Given this list of marker genes NCKIPSD, ST6GAL2, SAMD4A, RIMS1, PDLIM4, FOXP2, AKAP5, CYP39A1, GBP2, BACE2, RMC1, LSS, PRKAR2B, ZNF516, MYOCD, SPEG, KCTD5, CDK8, PRELID3B, HMGA2, GNAZ, KIF21B, FBXL15, SH3PXD2B, SIPA1L1, NXN, ATL1, ALKAL2, MTHFD2L, BCAS4, PODXL2, MXRA7, PHF13, HPSE2 (NCBI Gene Id 7354), C6orf226, KLHL4, CCDC88C, IRAG1, COQ10A, RALGPS2, ETHE1, CDK5, SYNC, DIXDC1, CDKL5, LAMA5, TMEM65, ZNF649, NR4A3 (NCBI Gene Id 8013), CHD1L, PHLDA3, RYBP, KLF7, ANGPTL2, MSRB3, HHIP, BEX1, BNC2, SRF, ELAC2, RASD2, IGSF3, AKIP1, BCL11A, HSD17B14, KIAA1217, SARM1, CPNE2, MIER2, ABCC1, TAF10, FBN2, BMPR1B, KLHL42, SEC11C, PDLIM3, UBE2H, FLNB, POU2F1, PAWR, GEMIN7, PICK1, NEGR1, HACD1, MALL, CRISPLD2, ADO, CASP9, ARC, PIK3C2B, CRIM1, KIF1B, NHSL3, NSG1 (neuronal vesicle trafficking associated 1), ITGB1BP2, JPH2, ADAMTS19, GREM2 (gremlin 2, DAN family BMP antagonist), CADM4, B3GALNT2, HEPH, MOAP1, PTPRF, MYEF2, FENDRR, SVIP, SLC27A6, CCNQ, CDH2, NTF3, OSTM1, FSD1, MDM1, MBNL1-AS1, HAGH, CAMTA2, CRABP2, DNM2, NT5DC3, EDN3, PITX2, BTN2A1 (NCBI Gene Id 11120), PACSIN2, HSPG2, CXXC4, HOXA4, MMP11, PGF, C12orf75, TOMM34, SLC8A1, P2RY1, ADAMTS6, SUPT3H, TOX, SOWAHC, RGS17, NTN1, FRZB, GTF2IRD1, SNTA1, MACROD2, PCP4L1, RPS6KA5, UBE2M, TSTD1, ACTG2, ENTPD1, ALKAL1, TSPAN2, NKD1, PTCH2, SYTL2, TOM1L1, SOX15, SYNJ2, ABHD8, WASF1, CDON, EXOSC6, PRKCE, BEX2, LRIG1, DRD2, BOK, PSEN2 (presenilin 2), RHOQ, CRMA, VEGFC, DEAF1, GARNL3, SIAH2, ZNF48, ARVCF, SLC38A1, CMIP, STK39, PPP1R12B, PLPP2 (phospholipid phosphatase 2), PTBP2, NEURL1B, IL17B, FST, FHDC1, TWIST1, CPXM2, GPR161, LRATD2, RSPO1, CITED4, IMPA2, MEIS3, MYL7, BTBD6, DDX20, PLA2G2A, CPT1A, LRRC3B, CHCHD7, VASP, TMTC2, RBPMS2, ITGA5, NUDT14, JAZF1, TUBB2B, CSRNP3, ZFR2, TSPAN18, MICALL1, STK38L, DNAH14, FILIP1L, ISL2, ACOT7, CACNA1H, GALNT9, TACC2, NAV2 (NCBI Gene Id 89797), NOG, CDC34, PDLIM5, SULF2, KLHL23, LMOD1, ERRFI1, AHNAK2, INTS13, KCNS3, FHL2, TST, ACTC1 (actin alpha cardiac muscle 1), HINT3, DMXL2, AKAP1, PDXP, TK1, CTPS1, FBXO32, PURB, REEP3, LASP1NB, EFNB3, MPPED2, GAREM2, SLC4A7, ANOS1 (anosmin 1), NTM, REC8, THNSL2, LINC02381, FBXO22, CDYL, FLRT3, PNCK, PRICKLE2, EFNA1, CASZ1 (castor zinc finger 1), TOB1, BICD1, REEP1, DHRS3, NPC1, OCIAD2, CYTH1, DCLK1, B9D1, CNN1, MID1IP1, ADK, PRKAB2, SYNGR2, ATL2, PGP, DUSP3, INKA2, CNOT6L, EHD4, ZNF703, USP12, CDC42EP3, MACIR, FBN3, CAMK1D, MRGPRF, SNX27, STRN3, TCEAL2, HRAS, FOXP4 (NCBI Gene Id 116113), PPP1R12C, GNB5, RFLNB, TNMD, CYRIB, DPP3, ARMC9, CCDC92, PDGFC, SLMAP, ASAP2, RNF217, MLLT1, KRT18, SRSF8, HAND2, NOL4L, ENPP1, KIAA1958, GALNT2, DCX, IQGAP2, FAXC, ECE1, NCAM1, DMWD, TRAF3IP2, FZD2, DUSP14, PHLDB2, PLXNA2, IL33, SMOC2, LRRN1, CAV2, KCTD10, RABGAP1, NKX6-1, DOCK9, OTUD5 (NCBI Gene Id 55593), PLP2, SVIL, TFAP2C, NIPAL4, METTL21A, GPM6A, XIST, LIX1, WFDC1, TGFBR1, ANO1 (NCBI Gene Id 55107), GCNT2, ADCY5, LINC02269, DDAH1, FGF7, MRAS, LDB3, TRAF5, CARMN, NAT14, DMKN, TBC1D7, SIPA1L2, MTCL1, FLNC, ZNF154, PPP1R3F, SLC25A25, EEPD1, PLEKHG4B, KLC2 (kinesin light chain 2), RPE65 (retinoid isomerohydrolase RPE65), HMGA1, CDK20, PRKACB, ANXA3, C1orf198, CPD, TMEM51, MEIS2, TRAPPC2 (trafficking protein particle complex subunit 2), ANO10, PGM5 (NCBI Gene Id 5239), RASSF3, APOC1 (NCBI Gene Id 341), KHK, AFMID, MYH11 (NCBI Gene Id 4629), SEMA4B, TPBG, PSME4, HOXC4, GLIPR1, PSD, STARD13, JAG1, ST6GALNAC5, ABHD17C, FREM2, PGM5-AS1, DHCR7, MSRB1, ANAPC15 (anaphase promoting complex subunit 15), RASGEF1B, SLC2A13 (solute carrier family 2 member 13), AIF1L, RPRD1B, PCSK7, FBXL22, TNNI1, SLC25A4, OXCT1, RABGAP1L, FGFR2, RAB33A, ETV6, KCNMA1, COL23A1, CISD1, SIGIRR, CD47, ADAMTS8, TENM1, CNTNAP3B, RPS6KA2, FOXF2, LRRC8A, TLE4, MDFIC, PFKFB3, SLC25A33, CNOT11, TMEFF1, MAPK14, CRTC3, SCAI, KITLG, RBM38, CDH3, SLC2A4, CIMAP3, LIG3, SLC2A1, NET1, AACS, VPS13A, ANKRD29, CTXN1, APOO, KCNMB1, BCAR1, NEDD4L, NPAS4, CD24, PCCA, LINC01770, PLCB3, AAK1, PPM1E, FRMD6-AS2, RNF207, TMEM106C, C3orf70, SCD, ECHDC2, RNF150, ZFHX4, PDCL3, KLHL5, GRB14, RAB9B, DUSP22, HSPB7, LDB2, HOMER2, OLFML2B, RCSD1, MAP1A, SLC2A8, DGKH, FRAS1, GLCCI1, RAB3C, TP53I11, ALDH1B1, GIPC1, SYNM, KPNA2, EVA1A, HOXC5, CDIP1, RGMB, GALE, EML1, SMYD3, KRT8, PIM1, ADAM19 (ADAM metallopeptidase domain 19), RSPO3, ARRDC1-AS1, RHOJ, TAGAP, FZD3, NETO2, ME2, ANKS1A, ILRUN, WFS1, KCND3, CRYL1 (NCBI Gene Id 51084), MRPS9, PVALB, BTN2A2 (NCBI Gene Id 10385, butyrophilin subfamily 2 member A2), PREB, ZEB1, CHKA, WDR77, PTS, DCAF15, HMGCS1 (3-hydroxy-3-methylglutaryl-CoA synthase 1), LIMS2, EPB41L1 (erythrocyte membrane protein band 4.1 like 1), NFIL3, HNRNPA1L3, RGMA, SORBS1, KCMF1, H2BC21, STRBP, THRB, RAMP1, AKIRIN1, ROGDI, IGFBP2, TINAGL1, MIPEP, GAS2 (growth arrest specific 2), INPP4A, DMD, KLHL36, IQCJ-SCHIP1, CSRP2, CUEDC1, CAP2, CORO1C, C17orf75, ASB2 (ankyrin repeat and SOCS box containing 2), RGS7, PPP2R2D, CHST15, PRUNE2, MIEN1, CFAP68, CAVIN2, CTHRC1, CTU1, RIOX1, GNPTAB, ISG15, GAB2, GCAT, TNFAIP8L1, CACNA1C, SPSB1, FBXL7, MAGI1, NPDC1, KRT17 (NCBI Gene Id 5103), SLA, MSC-AS1, FAM89B, TES, RNF175, VWA1, HHIP-AS1, LRWD1, DPP10, CHRM3, INSIG1, SINHCAF, CLMP, WIF1, PEDS1, PPP1R1A (NCBI Gene Id 5502), GFRA1, KPNA3, PRKAG2, UBALD1, RAI14, ESYT2, CBX6, NRG1, GRK6, SYNPO2, DYRK2 (dual specificity tyrosine phosphorylation regulated kinase 2), INSIG2, CXADR, ACOT1, here is a description of the gene set: from publication He P, Lim K, Sun D, Pett JP, Jeng Q, Polanski K, Dong Z, Bolt L, Richardson L, Mamanova L, Dabrowska M, Wilbrey-Clark A, Madissoon E, Tuong ZK, Dann E, Suo C, Goh I, Yoshida M, Nikolić MZ, Janes SM, He X, Barker RA, Teichmann SA, Marioni JC, Meyer KB, Rawlins EL (PMID 36493756) Human Gene Set: HE_LIM_SUN_FETAL_LUNG_C0_ACTC_POS_SMC_CELL studied in species Homo sapiens ACTC+ SMC